Given this list of marker genes Epn1, Kpna2, Hat1, Nnt, Srsf1, Wtap, Plagl1, Hells, Cks2, Id2, Ech1, Haus6, Ndn, Ube2m, Ywhab, Nup88, Ptov1, Apex1, Prim2, Casp8ap2, Cops3, Cyp1b1, Spcs2, Gm4739, Srsf6, Lage3, Nono, Map4, Rpa2, Ilf3, Tacc3, Rfc5, Rrm1, Nop58, Erdr1, Nme1, H2az2, Mrpl18, Mrpl48, Nfib, Sfrp2, Tia1, Ehmt2, Cuedc2, Ppp1r7, Cdc25c, Tmpo (NCBI Gene Id 71450), Ptn, Tardbp, Eif4g2, Vcan (versican), Cpt1a, Anapc5, Pros1, Nr2f2, Trip13, Col6a2, Ctbp1 (NCBI Gene Id 51972), Ahcyl, Loxl1, Gtf2i, Cd34, Odc1, Ube2e3, Capg, Nup85, Postn, Ttk, Mrpl20, Evl (NCBI Gene Id 14026), Arl2bp, Fignl1, Dock7 (NCBI Gene Id 67299), Ccnb2, Rxylt1, Anp32b, Marcks, Dtd1, Lsm2, Rbm3, Gusb, Foxg1, Psip1, Zfp26, Snrpa, Aurkb, Cetn2, Mcm2, Slbp, Ipo4, Nfyc (nuclear transcription factor-Y gamma), Ints8, Fmr1, Chrac1, Hmgn2, Tsen34, Strap, Gsdme, Hypk, Slc35a1, Carm1, P3h3 (prolyl 3-hydroxylase 3), Abcg2, Topbp1, Emc6, Mrps21, Gmnn, Rars2, Cdk4, Cavin3 (caveolae associated 3), Slirp, Hnrnpl, Pole2, Dnajc13, Rhoj, Hspa4, B9d1, Tubb2a, Psmb5, Hnrnpa1, Fstl1, Amd1, Tomm5, Rcbtb1, Naa38, Calm3, Erh, Stmn1, Wls, Lsm3, Rcn2, Gas2, Gcat, D17H6S56E-5, Ect2, Emp3, Echs1, Irak1 (interleukin-1 receptor-associated kinase 1), Jpt1, Haus3, Pbrm1, Anp32e, Pclaf, Nup35, Pdcd6ip, Fkbp4, Elof1, Incenp, Ndufb8, Sptssa, Psmd6, Has2, St7, Cxcl12, Slc38a4, Tufm, Gstz1, Racgap1, Psmc3, Prim1, Pcdh7, H2ax (H2A.X variant histone), Prelid1, Eif1ax, Larp7, Pnp, Met, Ncam1, Cpne1 (copine I), Smarce1, Sf3a3, Rasa1, Gja1, Nr2f1, Uhrf1, Pkp4, Set, Cks1b, C1ra, Pkd2 (NCBI Gene Id 77380), Cdc20, Tgfbi, Nfkb1, Mir5136, Rbl1, Cetn3, Tyms, Arglu1, Cfdp1, Gas1, Mcm4, Ptprk, Ppa2, Nde1, Ncbp2, Ndufa13, Luc7l3, Ctps2 (cytidine 5'-triphosphate synthase 2), Kif23, Mki67, Kif11, Ivd, Aurkaip1, Rsrp1, Cstf3, Clcn4, here is a description of the gene set: from publication Pal S, Vishwanath SN, Erdjument-Bromage H, Tempst P, Sif S (PMID 15485929) Protein arginine methyltransferases (PRMTs) have been implicated in transcriptional activation and repression, but their role in controlling cell growth and proliferation remains obscure. We have recently shown that PRMT5 can interact with flag-tagged BRG1- and hBRM-based hSWI/SNF chromatin remodelers and that both complexes can specifically methylate histones H3 and H4. Here we report that PRMT5 can be found in association with endogenous hSWI/SNF complexes, which can methylate H3 and H4 N-terminal tails, and show that H3 arginine 8 and H4 arginine 3 are preferred sites of methylation by recombinant and hSWI/SNF-associated PRMT5. To elucidate the role played by PRMT5 in gene regulation, we have established a PRMT5 antisense cell line and determined by microarray analysis that more genes are derepressed when PRMT5 levels are reduced. Among the affected genes, we show that suppressor of tumorigenicity 7 (ST7) and nonmetastatic 23 (NM23) are direct targets of PRMT5-containing BRG1 and hBRM complexes. Furthermore, we demonstrate that expression of ST7 and NM23 is reduced in a cell line that overexpresses PRMT5 and that this decrease in expression correlates with H3R8 methylation, H3K9 deacetylation, and increased transformation of NIH 3T3 cells. These findings suggest that the BRG1- and hBRM-associated PRMT5 regulates cell growth and proliferation by controlling expression of genes involved in tumor suppression. Genes up-regulated in NIH-3T3 cells (fibroblast) after knockdown of PRMT5 by RNAi. studied in species Mus musculus Mouse Gene Set: PAL_PRMT5_TARGETS_UP